The following is a description of a gene set: Genes predicted to be targets of miRBase v22 microRNA mmu_miR_497a_3p in miRDB v6.0 with MirTarget v4 prediction scores > 80 (high confidence targets). from publication Chen Y, Wang X (PMID 31504780) species: Mus musculus Mouse Gene Set: MIR_497A_3P, and this is the list of marker genes: Ppil3 (NCBI Gene Id 70293), Zbtb34, Wnt5a, Mypn, D5Ertd579e, Otx2, Zc3h14, Lypla2, Klf4 (NCBI Gene Id 269540), Ppargc1a, Fat4, Pmp22, P2ry1, Hlcs, Slc6a15 (NCBI Gene Id 319850), Lrrtm3, Kif5c, Spart, Slc30a9, Pou2af1, Ascl1, Gmfb, Map3k4, Myo5a, Myog, Tedc2, Bdnf, Tpd52, Gpr101, Asb8, Vcan, Ptpn2, Eif4h, Haus2, Rnf144a, Atad2b, Naf1, Arhgap17, Flrt1 (NCBI Gene Id 396184), Capn12, Sec31a, Atxn7, Cpne3, Lpgat1, Tmx4, Ppp4r2 (protein phosphatase 4, regulatory subunit 2), Spin1, Cenpw, Sytl4 (NCBI Gene Id 27359), Slc17a7, Wtap, Tmem108, Tnfrsf11a, Scrib, Hmgcll1, Ccnyl1, Serinc3, Heca, Msrb3, Tnrc6b, Tmem263, Myo9b, Ripor2, Pibf1, Ywhaz, Nav1, Slco5a1 (NCBI Gene Id 98178), Reck, Me2, Med14, Tnfrsf19, Pdcd6ip, Atp2b2, Tacc3, Gpnmb, Pdk1, Taok3, Ptbp3, Cpeb2, Ctdspl2, Qser1, Prex1, Slc9a6, Mdfic, Cd163 (CD163 antigen), Fam222b, Grk3, Crot, B020004C17Rik, Slc8a1, Sp3, Taf12, Lmo7, Ap4e1, Aebp2, Cdc42ep3, Sbno1, Gatad2a, Cpeb3, Zmym2, Pgam5, Fam124b, Ep300, Lpar1, Bach2, Pbx1, Pcgf5, Coa3, Ube2d2b, Thap12, Ndfip2, Tcim, Mbnl1, Nfkb1, Frg1, Nfat5, Serpind1, Slc25a4, Iws1, Hspa4l, Lgr4, Ust, Eif5a, Car11, Pea15a, Semp2l2a, Hmgn3 (NCBI Gene Id 94353), Med13, Mapk8, Nup98, Fabp3, Slc30a4, Rabgap1l, Rbbp4, Rassf9, Ypel1, Pbrm1, Zfp236, Fam169a, Rtn1, She, Cyp2ab1, Rbpj, Sh3rf2, Nhlh2, Naa35, Caprin1, Cycs, Kdm5a, Nr2f2, Vapa, Trp53inp1, Rad54l, Mllt10, Xrcc2, R3hdm1, Egr1, Setbp1, Kat6a, Dkk2, Gid4, Rpgrip1l, B3galt5, Agps, Pcyox1, Mycbp2, Cry1, Sobp, Ino80d, Cul4b, Zfand6